Given this list of marker genes JAG1, COQ5, PLOD1, PCDH15, FMR1 (NCBI Gene Id 5421), ATP6AP2 (ATPase H+ transporting accessory protein 2), TBC1D24 (TBC1 domain family member 24), GDAP1, SLC35C1, ITPR1, KCNN2, MTRFR, here is a description of the gene set: Reduced ability to walk in a straight line while placing the feet heel to toe. Human Gene Set: HP_IMPAIRED_TANDEM_GAIT species: Homo sapiens Impaired tandem gait